Given this list of marker genes MLH1, MND1, KASH5, EHMT2, SYCE2, P3H4, STAG3, DMC1, SYCE3, REC8, SYCP2, MAEL, TEX12, MSH5, IHO1, HORMAD1, FANCD2, MRE11, SHOC1, PRDM9, CCNB1IP1, UBE2B, ZCWPW1, TRIP13, RNF212B, TEX15, MEIOB, SIRT7, SYCP1, BRIP1, BAG6 (BAG cochaperone 6), MCMDC2, MAJIN, TERB2, C1orf146, NDC1, SYCE1, ANKRD31, AGO4, SPATA22, CCNE1 (cyclin E1), MSH4, C14orf39, SPO11, PSMC3IP, TERB1, MLH3, MEIOC, SUN1, TEX11, RNF212, SYCE1L, CCNE2, MEI4, here is a description of the gene set: species: Homo sapiens The meiotic cell cycle process where side by side pairing and physical juxtaposition of homologous chromosomes is created during meiotic prophase. Homologous chromosome pairing begins when the chromosome arms begin to pair from the clustered telomeres and ends when synaptonemal complex or linear element assembly is complete. Human Gene Set: GOBP_HOMOLOGOUS_CHROMOSOME_PAIRING_AT_MEIOSIS